The following is a description of a gene set: Any process that modulates the frequency, rate or extent of vascular smooth muscle cell dedifferentiation. Human Gene Set: GOBP_REGULATION_OF_VASCULAR_ASSOCIATED_SMOOTH_MUSCLE_CELL_DEDIFFERENTIATION species: Homo sapiens, and this is the list of marker genes: MIR221, PDGFB, MIR145, MIR182, OLFM2, MIR214